The following is a description of a gene set: Mouse Gene Set: CUI_CDC2_IFNA1_RESPONSE_UP Genes positively differentially expressed in cell type: cDC2 (conventional dendritic cell type 2) upon treatment with cytokine: IFN-α1 in mouse lymph nodes in vivo. from publication Cui A, Huang T, Li S, Ma A, Pérez JL, Sander C, Keskin DB, Wu CJ, Fraenkel E, Hacohen N (PMID 38057668) Cytokines mediate cell-cell communication in the immune system and represent important therapeutic targets. A myriad of studies have highlighted their central role in immune function, yet we lack a global view of the cellular responses of each immune cell type to each cytokine. To address this gap, the authors created the Immune Dictionary, a compendium of single-cell transcriptomic profiles of more than 17 immune cell types in response to each of 86 cytokines (>1,400 cytokine-cell type combinations) in mouse lymph nodes in vivo. A cytokine-centric view of the dictionary revealed that most cytokines induce highly cell-type-specific responses. For example, the inflammatory cytokine interleukin-1β induces distinct gene programmes in almost every cell type. A cell-type-centric view of the dictionary identified more than 66 cytokine-driven cellular polarization states across immune cell types, including previously uncharacterized states such as an interleukin-18-induced polyfunctional natural killer cell state. species: Mus musculus, and this is the list of marker genes: Relb, Coq2, 9930111J21Rik2, Ifi203, Fam241a, Cd47, Xrn1, Trim12c, Slc25a12, Vcam1, Tcstv4, Psme2, Mreg, Nlrc5, Aif1, Manf, Aftph, Sp100, Hspd1, Atp1b3, Plaur, Evl, Serpinb9, Il15ra, Bcl2a1a, Arfgef1, Ccnd1, Sat1, Psap, Ywhah, Frmd4a, Dtx3l, Cers6, Rab7b, Rbl1, Ppp1r2, Cnp, Krcc1, Fcer1g, Rnf19b, Ube2d3, Slirp, Parp14, Sar1a, Stk39, Lamp1 (NCBI Gene Id 234071), Hmgn3 (high mobility group nucleosomal binding domain 3), Parp12, Litaf, Oasl1, Il18, Hsph1, Casp3, Cd53, Tapbp (TAP binding protein), Zeb2os, Mat2a, Ccl12, Sema4d, Gbp8, Serpina3f, Ifit2, C3, Aip, Slc6a6, Mpp1, Nmral1, Ms4a4c, Tmem131, Znfx1, Sell, Tmem86a, Irf5, Aff1, Aim2, Chmp4b, Msmo1, Rhbdf2, Cebpb, Runx3, Ctsz, Dync1i2, Ifi209, H2-T24, Dennd1b, H3f3b, Slfn1, Hsh2d, Ppp1r11, Anxa4, Zc3hav1, Slc3a2, Cpne2, Dck, Fbxw17, Il27, Mcur1, Chmp5, Slfn9, Ifi205, Epsti1, Oas1g, Rufy3, Hspa8, Rnf135, Phf11b, Cyrib, Aida, Dpy19l1, Itm2b, Ywhae, Trim30b, Spg21, Scimp (NCBI Gene Id 547221), Vdac3, Dbnl, Spop, Phf11c, Pkib, Jpt1, Rigi, Sash1, Spi1, Irf8, Gatm, Ccl8, Psmb9, Acot9, Parp11, Usp18, Oas1a, Calm1, Tmbim6, Kdr, Crybg1, C1qb, Mif4gd, Nmi, Morc3, Fndc3a, Tmem51, Gng12, Ifit3b, Gca, Trim56, Ubr4, Bcl2a1b, Treml2, Hk3, Ube2e1, Il1rn, Gsdmd, Dop1b (DOP1 leucine zipper like protein B), Cflar, Lacc1, Pdcd2l, Dnajb11, Abcb1a, Selplg, Ptpn6, H2-T23, Hck, Shisa5, Mvp, Ikzf1, Oas3, Ifi214, Rab22a, Irf1, Atp6v0a2, Rbm8a, Ifit1, Vps37b (vacuolar protein sorting 37B), Sdcbp, Il4ra, Akr1a1, Tpm4, Ncf1, Ptafr, Oasl2, Nr1h3, H2-D1, Ubc, Tmem184b, Sh3glb1, Capza2, Coro2a, Lap3, Ifi35, Plin2, Ncoa7, Hsp90ab1, Mx1, Grina, Ssr3, Nod1, Psma5, Bcl2a1d, Slc29a3, Uba7, Nfkbie, M6pr, Gatad2a, Ly6a, Naa20, Procr, Xrn2, AB124611, Trim30c (NCBI Gene Id 633513), Keap1, Gpr108, Tent2, Peli1, Tmcc3, Usp25, Mthfr, Tspo (NCBI Gene Id 12257), Rab1a, Psma3, Tor1aip1, Tcf7l2, Pgd, Trim25, Zbp1, Fcgr4, Hdc, Mndal, Slc15a3, Oas2, Cited2, Ifi44, Atp6v1d, Rab8a, Prdx1, Tdrd7, Herc6, Ptms, Rasa4, Ogfrl1, Actr2, Ly86, Cmtm6, Dync1h1, Dnase1l3, Etv3, Tor3a, Dhx58, Il18bp, Gnb4, Stard3, Bag1, Glipr2, Mfsd12, Gbp9, Nsd3, Dok1, Grb2, Mov10, Phf23, Cfb, Tspan31, Dnaja1 (DnaJ heat shock protein family (Hsp40) member A1), Ywhaz, Vwa5a, Arf5, Dnajc13, Ccl2, Tle3, Mthfd2, Rab7, Ogfr, Ms4a6d, Arhgap30, Rab5c, Tmem106a, Sap30, Tfg, Selenow, Traf1, Slfn4, Fgl2, Cxcl10, AA467197, Ifih1, Lst1, Naa25, Xdh, Ppp1r9b, Anxa7, Gramd2b, Tex9, Ly6i, Lgals3, Rsad2, Tmpo, Helz2, Nt5c3, Parp9, Acp2, Adap1, Ifit3, Ass1, Eif2ak2, Atp13a1, Dennd1a, Tap2, Casp4, Arhgap22, Tesk1, Tlr7 (toll-like receptor 7), Rnf213, Asb13, Samd9l, Cmpk2, Ddx4, Hspa5, Zc3h7a (zinc finger CCCH type containing 7 A), Srsf3, Rbm43, Ms4a6b, Ciao2b, Tank, Trp53i11, Casp1, Mlkl, Id2, Plaat3, Bri3, Actg1, Trim14, Cxcl9, Marchf5, Necap2, Ctss, Isg20, Tagln2, Ifi211, Camk2d, Utp3, Psma2, Sppl2a (NCBI Gene Id 66552), Slamf8 (NCBI Gene Id 74748), Bex6, Tomm70a, Vcpip1, Pdcd10, Arhgef10, Cxcl16, Vps54 (VPS54 GARP complex subunit), Zcchc2, Dnaja2, Eif6, Prpf38a, Flnb, Morf4l2, Socs2, Tgm2, P2ry14, Psmb8, Daxx, Nqo2, Ccnd2, Alas1, Il10ra, Cox5a, Pdia6, Hsp90aa1, Tpx2, Bak1 (NCBI Gene Id 12018), Clic4, Cycs, Rtn4, Tmed5, Dcp2, Slc30a1, Il15, Ranbp2, Cstb, Scamp2, Gbp4, Cd52, Cd40, Calhm6, Rnf114, Arl6ip1, Arf6, Hat1, Ube2l6, Slc25a22 (solute carrier family 25 (mitochondrial carrier, glutamate), member 22), Metrnl, Ankrd12, Nrp1, Rnpep, Arl5a, Tnfsf10, Azi2, Dram1 (NCBI Gene Id 71712), Ly6c2, Pdgfb, Icam1, Macir, Trim12a, Snx10, Phyh, Usp15 (NCBI Gene Id 70921), Nfkbib, Creb5, Rrad, Atp6v1b2, Npc2, Themis2, Ilrun, Efhd2, Srgap2, Gadd45b, Sh3bp2, Cyba, Dnajc7, Phf11a, Lfng, Tcirg1, Tbl1x, Mbd2, Pfkp, Ifi208 (interferon activated gene 208), Psmb10, Dusp2, Cd86, Ift172, Bst2, Cct3, Lgals8, Slco3a1, Il21r, Arid5a, Flt1, P4ha1, Adar, Laptm4a, Cd69, Stxbp3, Pcgf5, Nectin2, Wfdc17, Dusp5, Trip12, Phc2, Cd83, Rbms1 (NCBI Gene Id 98885), Axl, Hipk2, Serpina3g, H2-K1 (histocompatibility 2, K1, K region), Spred1, Ccdc86, Casp8, Cpne3, Cd300lf, Setdb2, Cd72, Larp1, Tmem219, Ms4a4b, Socs3, Pnpt1, Trafd1 (TRAF type zinc finger domain containing 1), Zup1, Gbp7, Smchd1, Psma4, Clec2d, Marcksl1, Lyn, Pttg1, Snx6, Plod3, Gmppb, Trim34a, Tapbpl, Ggct, Adap2, Snx2, Ncf4, Fyn, Fcgr1, Ndrg1, Tlk2, Zyx, Arf4, Batf2, Slfn8, Stat1, Phf11d, Mcl1, Cldnd1, Polb, Parp10, Ly6e, Ifit1bl1, Hspe1, Stat2, Grn, Rap1b, Cgas (NCBI Gene Id 214763), Mxd1, Gch1, Mitd1, Irgm1, Cd274, Selenot, Ndufs4, Pnp, Pdia3, Tmsb10, Nono, Cyria, Ifi207, Gbp5, Sass6, Ifitm3, Tent4a, Ascc3, Cndp2, Synj1, Ddx60, Rilpl1, Tap1, Phf6, Pitpnm1, Gbp3, Serinc3, Cdkn1a, Gtpbp2, Nrros, Ndst2, Max, Trim30d, Ywhag (tyrosine 3-monooxygenase/tryptophan 5-monooxygenase activation protein, gamma polypeptide), Ostf1, Psme1, Ccl5, Cd164, Peds1, Pdk3, Isoc1, Ifi204, Socs1, Acer3, Sp110, Sp140, Cacybp, Rnh1, Bbx, Endod1, Cdc42, Rtp4, Tbc1d1, Tor1aip2, Plau (plasminogen activator, urokinase), Klrk1, Tgfb1, Timeless, Tpst1, Bcl3, Ifi27l2a, Etnk1, Pml, Ube2l3, Prkcd, Lamp2, Il2rg, Unc93b1, Cyth4, Fmnl2, Usp12, Glrx, Zfp800, Asb2, Esd, Rab11a (RAB11A, member RAS oncogene family), Cnn3, G3bp2, Nrp2, Ankfy1 (NCBI Gene Id 11736), Pgap2, Mcmbp, Stat3, Aplnr, Stx11, Irf7, Irgm2, Lgals3bp, Vav1, Cds1, H2-T22, Rnf34, Mpeg1, Sgcb, Igtp, Ifi206, Rab8b, Csrp1, Kpna3, Prkx, Anxa5 (annexin A5), Tpm3, Nampt, Ppa1, Sct, Ifi213, Aldh1b1, Actr3, Hif1a, Ifitm6, B4galt5, Slfn5, Samhd1, Acadl, Dek, Svbp, Trim30a, Setd3, Txn1, Lgals9, Sco1 (SCO1 cytochrome c oxidase assembly protein), Vamp8, Ms4a6c, Gbp2, Adgre5, Sdc3, Rap2c, Map2k1, Iigp1, Isg15, Slfn2, Klra2, B2m, Myd88, Lrp8, Tbrg1, Xaf1, Apobec3, Gna13, Plekho2, Hpse (NCBI Gene Id 231508), Ldlr, Ifi47